Given this list of marker genes Hid1, Nucb2, Golga5, H2-D1, H2-K1, H2-Q2, Gorasp2, St6gal1, Yipf6, Slc10a7, H2-Q10, B3galt6, Yipf1, H2-Q6 (histocompatibility 2, Q region locus 6), H2-Q1, Pcsk5, H2-Q4, Glg1, Yipf2, Tmem59, Gosr1, St3gal1, H2-Q7, Man2a1, here is a description of the gene set: Mouse Gene Set: GOCC_GOLGI_MEDIAL_CISTERNA The middle Golgi cisterna (or cisternae). species: Mus musculus